The following is a description of a gene set: Human Gene Set: GOBP_UBIQUINONE_METABOLIC_PROCESS The chemical reactions and pathways involving ubiquinone, a lipid-soluble electron-transporting coenzyme. species: Homo sapiens, and this is the list of marker genes: COQ8B, COQ7, COQ6, ADCK2, AIFM2, COQ5, NQO1, FDX2, COQ3, COQ2, COQ8A, PDSS2, PDSS1, NDUFA9, FDXR, RTN4IP1, COQ4, COQ9 (coenzyme Q9), UBIAD1, PPTC7, STARD7